The following is a description of a gene set: The process in which tubulin alpha-beta heterodimers begin aggregation to form an oligomeric tubulin structure (a microtubule seed). Microtubule nucleation is the initiating step in the formation of a microtubule in the absence of any existing microtubules ('de novo' microtubule formation). Human Gene Set: GOBP_MICROTUBULE_NUCLEATION studied in species Homo sapiens, and this is the list of marker genes: CEP192, MECP2, CLASP1, DCTN1, HAUS8, NDEL1, TUBGCP6, HAUS6, EML2, HAUS4, TUBGCP3, HAUS5, HAUS1, PCNT, CLASP2, TUBGCP4, SSNA1 (SS nuclear autoantigen 1), MZT1, NDE1, TUBG1, SLAIN1, BLOC1S2, CCDC66, HAUS2, CENPJ, TPPP, HSPA1B, PDE4DIP (NCBI Gene Id 9659), TPX2, TUBGCP2, NME7, NEDD1, TUBGCP5, SLAIN2, NIN, CSNK1D, HAUS3, GOLGA2, TUBG2, GIT1, PAK1, CCDC57, RANBP9, HAUS7, CKAP5, HSPA1A, ARHGEF7, AKAP9